The following is a description of a gene set: To be excreted in urine, glutathione conjugates undergo several hydrolysis steps to form mercapturic acids which are readily excreted. The first step is the hydrolysis of a gamma-glutamyl residue from the conjugate catalysed by gamma-glutamyltransferases (GGTs). These are membrane-bound, heterodimeric enzymes composed of light and heavy peptide chains. Extracellular glutathione (GSH) or its conjugates can be hydrolysed to give cysteinylglycine (CG, or CG conjugates) and free glutamate (L-Glu). Hydrolysis of GSH provides cells with a local cysteine supply and contributes to intracellular GSH levels. Defects in GGT1 can cause glutathionuria (GLUTH; MIM:231950), an autosomal recessive disorder characterised by increased GSH concentration in the plasma and urine. Mutations that cause GLUTH can occur in both chains of the GGT1 dimer. part of: Metabolic disorders of biological oxidation enzymes Reactome Pathway: Defective GGT1 in aflatoxin detoxification causes GLUTH studied in species Homo sapiens, and this is the list of marker genes: GGT1